Given this list of marker genes YY1, PIEZO2, ABL1, NUP85, RAI1, RFX7, SATB1, FBXO11, H4C9, PIK3CA, SETD5, TCF20, NAA10, ATR, EBF3, TRAIP, IFT43, VPS13B, NBAS, MBD5, SVIL, MEIS2, CTCF, FLNA (filamin A), RBBP8, CREBBP, ALG12, IGF1R, PRKG2, SUZ12, TRAF7, NXN, EP300, SLC26A2, DCPS (decapping enzyme, scavenger), GALNT2, BCOR, FLNB, SMOC1 (SPARC related modular calcium binding 1), AEBP1, CANT1, BPTF (NCBI Gene Id 348241), WBP4, DSP, NSUN2, FBXW11, LTBP4, RHOA, CILK1, GMNN, MTX2, ARID1A, PCNT, HERC2, HEATR3, COX7B, ADNP, B3GAT3 (beta-1,3-glucuronyltransferase 3), SLC32A1, EFNB1, COL11A2, CHST11 (carbohydrate sulfotransferase 11), CUL4B, DNA2, ROR2, SMARCD2, ATRIP, MAPK1, DPM1, COL1A2 (NCBI Gene Id 1278, collagen type I alpha 2 chain), ARID1B, SMARCE1, CRKL, NBN, SMARCA2, TRIO, CENPE, SETBP1, TBX4, MAN2C1, IFT52 (NCBI Gene Id 51098), TRIP12, KAT6A, SALL4, IFT57, CHST3, BCR, TNNT3, ESCO2, CEP152, EZH2, DDX59, BMP2, LIG4, NSD1, PLK4, here is a description of the gene set: studied in species Homo sapiens A widely spaced gap between the first toe (the great toe) and the second toe. Sandal gap Human Gene Set: HP_SANDAL_GAP